Given this list of marker genes Osm, Fcer1g, Ifi206, Gnl3, Arpc2, Irf8, Ccnd2, Gzmb, Prf1, Bst2, Coro1a, Actg1, Ptprcap, Slamf7, Tubb4b, Gns (NCBI Gene Id 97675), Gzma, Pfn1, Hspa8, Ncr1, Metrnl, Isg15, Cotl1, here is a description of the gene set: Cytokines mediate cell-cell communication in the immune system and represent important therapeutic targets. A myriad of studies have highlighted their central role in immune function, yet we lack a global view of the cellular responses of each immune cell type to each cytokine. To address this gap, the authors created the Immune Dictionary, a compendium of single-cell transcriptomic profiles of more than 17 immune cell types in response to each of 86 cytokines (>1,400 cytokine-cell type combinations) in mouse lymph nodes in vivo. A cytokine-centric view of the dictionary revealed that most cytokines induce highly cell-type-specific responses. For example, the inflammatory cytokine interleukin-1β induces distinct gene programmes in almost every cell type. A cell-type-centric view of the dictionary identified more than 66 cytokine-driven cellular polarization states across immune cell types, including previously uncharacterized states such as an interleukin-18-induced polyfunctional natural killer cell state. from publication Cui A, Huang T, Li S, Ma A, Pérez JL, Sander C, Keskin DB, Wu CJ, Fraenkel E, Hacohen N (PMID 38057668) studied in species Mus musculus Genes positively differentially expressed in cell type: NK cell upon treatment with cytokine: IFN-ε in mouse lymph nodes in vivo. Mouse Gene Set: CUI_NK_CELL_IFNE_RESPONSE_UP